Given this list of marker genes Tnfrsf1b, Il1r2, Il18bp, Ifnar2, Ccrl2, Park7, Nlrp2, Csf1r, Prp2rt, Il2rg, Ghr, Tgfbr2, Il12a, Lrrc32, Il2rb, Ltbp3, Grem2, Trim16 (tripartite motif-containing 16), Il17f, Il18r1, Chrdl2, Tnfrsf14, Tnfrsf1a, Osmr, Ager, Scube3, Tgfbr3l, Chrd, Nog, Gbp2b, Itgb1, Il1rn, Cxcr6, Il5ra, Klhl20, Ccr1l1, Eng, Il1rl1, Il9r, Ccr9, Lifr, Tgfbr3, Acvr1, Cxcr1, Grem1, Agrn, Ltbp1, Il31ra, Ltbp4, Adam17, Pou5f1, Crlf1, Ccr7, Cops5, Hyal2, Ccr10, Cxcr2, Mmp8, Tsku, Hjv, Hmgb1, Tgfb3, Wfikkn2, Csf3r, Elane, Pdpn, Ackr3 (atypical chemokine receptor 3), Tnfrsf11a, Ucma, Bmpr1b, Tmc8, Cx3cr1, Il23r, Acvr2b, Casp1, Il13ra1, Fzd4, A2m, Fgf2, Cd44, Wfikkn1, Twsg1, Ifngr1, Ccr2, Gbp2, Il12rb2, Ccr8, Cd74, Tcap, Il13ra2, Il22ra1, Nbl1, Il11ra1, Cxcr5, Vasn, Il20rb, Ifnar1, Sostdc1, Cxcr4, Il11ra2, Plp2, Il6ra, Il12b, Sost, Ccr6, Il1rapl1, Itgav, Gdf5, Ackr2, Comp, Cer1, Il22ra2, Il1r1, Ccr5, Il20ra, Acvrl1, Il12rb1, Ackr4, Itgb3, Cntfr, Bmpr2, Bgn, Il10ra (NCBI Gene Id 16154), Ccr3, Prlr (prolactin receptor), Il6st, Ccr4, Cd36, Ackr1, Traf2, Thbs1, Xcr1, Itga4, Chrdl1, Il2ra, Lepr, Nrros, Tgfbr1, Cd4, Hax1, Bmpr1a, Ccr1, Kit, Zfp36, Cxcr3, Cd109, here is a description of the gene set: studied in species Mus musculus Mouse Gene Set: GOMF_CYTOKINE_BINDING Binding to a cytokine, any of a group of proteins that function to control the survival, growth and differentiation of tissues and cells, and which have autocrine and paracrine activity.